Given this list of marker genes Ell3, Prph, D930020B18Rik, Scn5a, Prox2, Hmx1, Abhd15, Ppef1, C78859, Sdk1, Syt13, Rprm, Gm2824, 9530059O14Rik, Nrsn1, Tbc1d9, Cacng5, 4930419G24Rik, Shc2, Scn10a, Neurod1, Gm15723, Rgs11, Cerkl, Serpinb8, Syt2, Gm19445, Fam135a, Synm, Wscd2, Prkg1, Pappa2, Clgn, Ebf1, Rap1gap2, Phc2, Cyfip2, Tlx3, Csnk1g1, Chst8, Smim35, Hip1, Rims3, Rapgef6, Syn2, Pcgf1, Drgx, Pirt, Scn7a, Enah, Hrk, Dclk3, Tlx2, Gm13629, Ptprr, Pde4a, Rtn4rl2, Tmem178b, Itga7, Bdkrb2, Ntrk1 (neurotrophic tyrosine kinase, receptor, type 1), C230012O17Rik, Rxfp3 (NCBI Gene Id 239336), 2610028E06Rik, Adam11, Npr2, P2rx3, Cacna1e, Kcnh6 (NCBI Gene Id 192775), Zfp78 (zinc finger protein 78), Htr3b, Synpo, Rtn4rl1, Cadm1, Exoc1l, Prkce, Kcnmb2, Xkr7, Slco4a1, Ckmt1, Mreg, Gm13648, Ppp1r17, Vwa5b2, Thsd7b, Or2c1, 4930473D10Rik, Amigo1, Ccer2, Cpne4, Fam217a, Hs3st2, Kif13b, Pou4f1, Asic3, Pcdh20, Kif19a, Fam89a, Sgpp2, Trim66, Pex5l, Grxcr1, Gm16036, Gm16364, Sh3rf3, Tacc2, Pde4dip, Rgs4, Ccser2, B4galnt3, Gm13791, Ppp1r14a, Tesc, Rnf150, Trhde, Plekhd1 (NCBI Gene Id 217682), Clmp, Kcnj12, Htr3a, Ankrd24, A430093F15Rik, Ccdc92, Kcnh1, Cep85l, Ppp1r1c, Kctd16, Ttll7, D130052B06Rik, Mapk8ip1, Scn9a, Cdhr1, here is a description of the gene set: Mouse Organogenesis Cell Atlas (MOCA) DE_gene_main_cluster.csv, fold.change>=1.5, qval<0.05, pval<0.05 Mouse Gene Set: DESCARTES_ORGANOGENESIS_SENSORY_NEURONS from publication Cao J, Spielmann M, Qiu X, Huang X, Ibrahim DM, Hill AJ, Zhang F, Mundlos S, Christiansen L, Steemers FJ, Trapnell C, Shendure J (PMID 30787437) species: Mus musculus